Given this list of marker genes IL15RA, RASGRP1 (RAS guanyl releasing protein 1), TOX, AXL, ZBTB1, GAS6, STAT5B, IL21, IL15, STAT5A, here is a description of the gene set: species: Homo sapiens Any process that activates or increases the frequency, rate or extent of natural killer cell differentiation. Human Gene Set: GOBP_POSITIVE_REGULATION_OF_NATURAL_KILLER_CELL_DIFFERENTIATION